The following is a description of a gene set: Spontaneous development of hematomas (hematoma) or bruises without significant trauma. Spontaneous hematomas species: Homo sapiens Human Gene Set: HP_SPONTANEOUS_HEMATOMAS, and this is the list of marker genes: GP1BA, FYB1, WAS, F10, SERPINE1, ATP7A, F8, F5, ITGA2B, GP9, ITGA2, CD109, F13B, ITGB3, F13A1, GP1BB, PRKACG, COG8, WIPF1 (WAS/WASL interacting protein family member 1)